Given this list of marker genes RBP5, MPDZ, KCNB1, RETSAT, XYLB, N4BP2L1, C4BPA, ACMSD, CBR1, MAGIX, SIAH2, ACSL6, ACYP2, TMT1A, MTG2, GLYAT, SOD1, HIBADH (3-hydroxyisobutyrate dehydrogenase), APOA5, ENPP7, PINK1, POR (NCBI Gene Id 96440), C9, REEP5, MCEE, SLC22A18AS, RGN, ABCB8, PDK2, ABCB11, NGEF, DDT, IVD, ALDH1B1, TMT1B, SDC1, HSD17B10, ALPL, FABP4, NR1I2, ABCA6, NR1I3, SHBG (NCBI Gene Id 6462), LRP1, ACY1, CPT2, OPRPN, CRAT, IGFBP2, RMDN3, ACY3, PNPO, HNF4A, CDHR5, TM6SF2, ABCA8, SLC1A1, LARP4, UQCR11, NDUFS7, GCLC, GADD45A, PMS2P2 (NCBI Gene Id 5380), here is a description of the gene set: Human Gene Set: VILLANUEVA_LIVER_CANCER_KRT19_DN In approximately 70% of patients with hepatocellular carcinoma (HCC) treated by resection or ablation, disease recurs within 5 years. Although gene expression signatures have been associated with outcome, there is no method to predict recurrence based on combined clinical, pathology, and genomic data (from tumor and cirrhotic tissue). We evaluated gene expression signatures associated with outcome in a large cohort of patients with early stage (Barcelona-Clinic Liver Cancer 0/A), single-nodule HCC and heterogeneity of signatures within tumor tissues. Genes under-expressed in KRT19-positive hepatocellular carcinoma (HCC). studied in species Homo sapiens from publication Villanueva A, Hoshida Y, Battiston C, Tovar V, Sia D, Alsinet C, Cornella H, Liberzon A, Kobayashi M, Kumada H, Thung SN, Bruix J, Newell P, April C, Fan JB, Roayaie S, Mazzaferro V, Schwartz ME, Llovet JM (PMID 21320499)